Given this list of marker genes Alb, Apoc3, Pltp, Apoe, Apoc2, Abcg1, Apoa1, here is a description of the gene set: electronically inferred by orthology from the curated human pathway Reactome Pathway: HDL remodeling species: Mus musculus This event has been computationally inferred from an event that has been demonstrated in another species.<p>The inference is based on the homology mapping from PANTHER. Briefly, reactions for which all involved PhysicalEntities (in input, output and catalyst) have a mapped orthologue/paralogue (for complexes at least 75% of components must have a mapping) are inferred to the other species. part of: Plasma lipoprotein remodeling